The following is a description of a gene set: Genes up-regulated in macrophages: wildtype versus SOCS3. from publication Lang R, Pauleau AL, Parganas E, Takahashi Y, Mages J, Ihle JN, Rutschman R, Murray PJ (PMID 12754506) Human Gene Set: GSE411_WT_VS_SOCS3_KO_MACROPHAGE_UP species: Homo sapiens Effects of SOCS3 on the transcriptional response of bone marrow-derived macrophages to IL-6. Fetal liver cells from SOCS3+/+ or SOCS3-/- embryos were used to reconstitute recipient mice. Donor derived bone marrow from these mice was differentiated to macrophages. Macrophages were either unstimulated, or stimulated for 100 or 400 minutes with 10 ng/ml IL-6., and this is the list of marker genes: UBQLN1, RELN, AKR1A1, CENPQ, REEP4, RALA, RAB9A (NCBI Gene Id 9367), UQCRFS1, UBE2M, APOC2, DERL1, PADI4, OIP5, TP53INP2, ADK, RARB, RFTN1, UXS1, CEP76, ATXN7L1, NEDD8, MRPL18, SAPCD2, PAPOLA, TKTL1, TMCO1, NBN, PPP1CC, DLGAP5, PEA15, DERL3, CUTA, NADK2, ATXN10, TAX1BP3, BPGM, SGTA, TRAIP, KCMF1, PITPNC1, CBX3, POP4, THOC7, ANKMY2, SMN1, SSBP3, UBE2I, ILDR1, SDHD, E2F3, TFRC, MCTP2, NDUFB8 (NADH:ubiquinone oxidoreductase subunit B8), PRPS1, DROSHA (drosha ribonuclease III), SERHL2, BTNL2, CACYBP, TMEM51, RRP7A, PPP6C, UBE2D2, WDR62, CCP110, U2AF1, MRPS18A, OAZ1, HSD17B12, GMPS, CDC14B, PIMREG, FDX1, IMMT, CENPT, LTK (leukocyte receptor tyrosine kinase), GRHL1, ATP5MC3, RPS27L, FAM83E, STX7, ACKR2, ATP6V1E1, ELOC, VGLL4, ST3GAL5, FAS, CCDC34, PPIL1, MNS1, ZFAND3, CS, MAN1C1, ACBD6, HSPA1B (NCBI Gene Id 3304), SORD, DHFR, MCM4, UBE2J1, PTER, NHP2, PMVK, MTHFD1L, EHF, TOX2, BAG2, CENPV, GEMIN6, GLA, MVD, TEN1, UCP2, CKS2, PBDC1, ARHGEF39, HMGN5, RRM2B, SLC36A4, HIRA, TK1, HPSE, ADPRH, SELENOP, DTNBP1, ERI1, EYA3, SPEF1, UBE2E3, C16orf87, GNA13, SUV39H2, HERPUD1 (homocysteine inducible ER protein with ubiquitin like domain 1), DDX19A, DNAJA2, CBX4, UBAP2L, B9D1, ASXL1, HDAC1, SLAMF7, F9, LMF2, ARHGEF12, BID, PHF6, DTWD2, SIK3, SELENON, SH3BGRL, HEMGN, CELSR1, TIPIN, STXBP1, SBF2, GINS1, TDP1, KCTD17, MSH6, DSN1, SULT1A1, MLF1, CDK2AP2, INTS6L, FGF11, TYMS, GRSF1, NSMCE2, EIF5B, LPXN, ANAPC16, CNOT9, MSRA, ADAP1, GCLC, SLC23A1, UBE2E1, CENPF, KNL1, MRPL21, WDR70, NEU1, DGKE, ELL2, DHRS1, MTPN, SEPTIN12, NSDHL, ACYP2, OSGIN2, IPO7, SNRPD1, CA13, MND1, UCHL5, NCAPD3, NR4A3, LSM14A, RPA3, MRPL46, FARS2, CACNA1S